The following is a description of a gene set: species: Mus musculus Human Gene Set: SCHAEFFER_PROSTATE_DEVELOPMENT_AND_CANCER_BOX6_DN Cancer cells differentiate along specific lineages that largely determine their clinical and biologic behavior. Distinct cancer phenotypes from different cells and organs likely result from unique gene expression repertoires established in the embryo and maintained after malignant transformation. We used comprehensive gene expression analysis to examine this concept in the prostate, an organ with a tractable developmental program and a high propensity for cancer. We focused on gene expression in the murine prostate rudiment at three time points during the first 48 h of exposure to androgen, which initiates proliferation and invasion of prostate epithelial buds into surrounding urogenital sinus mesenchyme. Here, we show that androgen exposure regulates genes previously implicated in prostate carcinogenesis comprising pathways for the phosphatase and tensin homolog (PTEN), fibroblast growth factor (FGF)/mitogen-activated protein kinase (MAPK), and Wnt signaling along with cellular programs regulating such 'hallmarks' of cancer as angiogenesis, apoptosis, migration and proliferation. We found statistically significant evidence for novel androgen-induced gene regulation events that establish and/or maintain prostate cell fate. These include modulation of gene expression through microRNAs, expression of specific transcription factors, and regulation of their predicted targets. By querying public gene expression databases from other tissues, we found that rather than generally characterizing androgen exposure or epithelial budding, the early prostate development program more closely resembles the program for human prostate cancer. Most importantly, early androgen-regulated genes and functional themes associated with prostate development were highly enriched in contrasts between increasingly lethal forms of prostate cancer, confirming a 'reactivation' of embryonic pathways for proliferation and invasion in prostate cancer progression. Among the genes with the most significant links to the development and cancer, we highlight coordinate induction of the transcription factor Sox9 and suppression of the proapoptotic phospholipid-binding protein Annexin A1 that link early prostate development to early prostate carcinogenesis. These results credential early prostate development as a reliable and valid model system for the investigation of genes and pathways that drive prostate cancer. from publication Schaeffer EM, Marchionni L, Huang Z, Simons B, Blackman A, Yu W, Parmigiani G, Berman DM (PMID 18794802) Early prostate development genes (down-regulated at 48 hr dihydrotestosterone) which are also down-regulated in high grade prostatic intraepithelial neoplasia (PIN) vs invasive cancer., and this is the list of marker genes: PTGR1, SOX9, ID4, SCNN1A, AGTR1